The following is a description of a gene set: part of: Defective homologous recombination repair (HRR) due to BRCA2 loss of function species: Homo sapiens This pathway describes truncating mutations in BRCA2 that result in mutant proteins lacking nuclear localization signals (NLSs) in the C-terminal domain. These truncated BRCA2 proteins mainly localize to the cytosol, impairing the ability of BRCA2 mutants to participate in homologous recombination repair (HRR) in the nucleus. Truncating mutations are the most frequent BRCA2 mutations detected in cancer. Reactome Pathway: Impaired BRCA2 translocation to the nucleus, and this is the list of marker genes: SEM1, BRCA2